Given this list of marker genes Napa, Snap47, Stxbp5, Snap29, Stx18, Cplx4, Stxbp5l, Snap25, Cplx1, Vamp9, Vamp3, Vamp2, Stx17, Stx7, Stx5a, Snx4, Ykt6, Bnip1, Syn2, Gosr2, Vamp1, Stx16, Bet1, Doc2b, Stx2, Stx6, Stx3 (NCBI Gene Id 20908), Bloc1s6, Stx4a, Cplx2, Cplx3, Use1, Napb, Stx19, Stx1b, Stx12, Stx11, Stx8, Vamp4, Bet1l, Sec22b, Vamp8, Vti1b, Napg, Vti1a, Stx1a, Snap23, Gosr1, here is a description of the gene set: studied in species Mus musculus Mouse Gene Set: GOCC_SNARE_COMPLEX A protein complex involved in membrane fusion; a stable ternary complex consisting of a four-helix bundle, usually formed from one R-SNARE and three Q-SNAREs with an ionic layer sandwiched between hydrophobic layers. One well-characterized example is the neuronal SNARE complex formed of synaptobrevin 2, syntaxin 1a, and SNAP-25.